Given this list of marker genes Dkc1, Pus3, Pus1, Pus7, Pus10, Rpusd3, Rpusd2, Pusl1, Trub1, Trub2, Rpusd1, Pus7l, Rpusd4, here is a description of the gene set: Catalysis of the reaction: a uridine in RNA = a pseudouridine in RNA. Conversion of uridine in an RNA molecule to pseudouridine by rotation of the C1'-N-1 glycosidic bond of uridine in RNA to a C1'-C5. Mouse Gene Set: GOMF_PSEUDOURIDINE_SYNTHASE_ACTIVITY species: Mus musculus